Given this list of marker genes CAV1, HMGB1, CLEC12B, NLRC4, CD180, TAX1BP1, KLRC4, REG3G, RNF216, BIRC2, NFKBIA (NFKB inhibitor alpha), EIF2AK4, PTPN22, SYT11, RNF135, ITCH, KIR2DS2, NR1H4, IRF7, MNDA, POLR3F, EVPL, XRCC6, OAS3, MATR3, RAB11FIP2, OASL, DDX60, MAVS, NFKBIL1, POLR3G, AP3B1, CNOT7 (NCBI Gene Id 29883), RNF170, CARD16, OTUD4, USP15, GRN, DEFB114, PLA2G5, RNF144A, KLRC2, HSP90AA1, UNC93B1, CLEC7A, PELI1, PTPN6, PRKAA1, SELENOK, INPP5D, TRAF3IP2, NLRX1, MIR17, CXCL6, GSDME (NCBI Gene Id 1687), CD300H, RTN4, LSM14A, TRIM5, CR1, TRAF3IP3, YTHDF2, MIR200C, LY86, FBXO38, FLOT2, ZC3HAV1, PQBP1, TLR10, MAP3K7, PYDC1, KCNK6, SMIM30, BMP6, EIF4E2, KLRK1, ZDHHC11, EREG (epiregulin), METTL3, TRIM21, MAPK3, FOXP3, MIR146A, DDX41, CHUK, MIR20A, STAT5A, PTPN11, TRIM44, TLR3, CLEC6A, IL17A, SYK, PIK3R1, AKT1 (NCBI Gene Id 207), CD1D, CD37, GKN2, TBK1, USP18, CYBA (NCBI Gene Id 1535), PPP6C, NCF1, IL27, CD226, TSPAN6, MYD88, RNF31, A2M, KLRC3, SLC15A4, SLC15A3, DDX39A, RNF115, APPL2, DTX3L (NCBI Gene Id 151636), OTOP1, OTULIN, TREML4, RASGRP4, FCN1, NLRP1 (NLR family pyrin domain containing 1), CLEC4E, ARRB2, CARD8, TNFAIP3, HCK, MIR21, RNF125, IRF5, NMI, PAK1, PIK3AP1, NECTIN4, HLA-F, TLR5, PPP2R3C, SQSTM1, KLHL22, AHR, COLEC12, LILRB1, USP50, ZMPSTE24, FADD, IL15, CREBBP, EP300, CCDC134, HLA-E, FGL2, TRIM31, SFPQ, FFAR2, ECSIT, ATG12, PTPN1, MIR140, IRGM, LYAR, MMRN2, SMPDL3B, CALHM6, GFI1, SARM1 (NCBI Gene Id 23098), MBL2, HCFC2, LAMP1, NLRP10, PGC, SLAMF8, IRF3, PYDC2, TAB1 (NCBI Gene Id 10454), NR1D1, MAP2K6, DHX9, S100A9, HLA-A, PIM1, RSAD2, NFE2L2, TICAM2, TRIB1, VAV1, TRIM65, ZNRF1, CCDC92, GRB2, FBXL2 (NCBI Gene Id 26008), POLR3B, MAPKBP1, NOP53, ATG5, CD55, PAK2, TIGAR, RAET1G, PPP2CA, CD300E, KCNJ8, SPN, SIGLEC16, BCL10, TARBP2 (TARBP2 subunit of RISC loading complex), IL23R, MIR708, RBM47 (RNA binding motif protein 47), TRIM38, TRIL, PYCARD, NR1H3, IFIH1, ABHD17A, STMP1, NLRP3, RPS19, NINJ1, KCNK13, PPM1B, ZNFX1, TRAF3IP1, BECN1, IKBKB, NECTIN2, IRAK1, IKBKE, ESR1, FOXP1, TKFC, GBP2, COLEC10, APP, APOBEC3G, RNF34, TRIM41, SIRT2, AP1G1, MAPKAPK3, INS, FCRL3, MMP12, CEACAM1, SIGIRR, TLR1, PRKD1, MAPK8, CEP63, KLRB1, SERPING1, MIR520B, FYN, NPLOC4, IL23A, ARG1, ATAT1, CACTIN, CD14, TRIM11, RASGRP1, IFNB1, CREB3, ELP6 (elongator acetyltransferase complex subunit 6), HSPA1B, PLSCR1, PDCD1 (NCBI Gene Id 56179), IFNLR1, PPARG (peroxisome proliferator activated receptor gamma), MED1, TTLL12, SLC46A2, NAGK, MIR200B, TLR6 (NCBI Gene Id 10333), KAT5, USP17L2, CD300A, PRKCE, IRF1, MARCHF5, PAK3, MFHAS1, HLA-B, NEK7, LRRC19, CD274, SAMHD1, KLK3, DTX4, XIAP, SASH1, HSPA8, SERPINB4, STING1, HLA-G, GDI1, IL12A, CYLD, ZDHHC5, HSPA1A, TLR9, HPX, SH2D1B, GPR108, MIR26B, ANKRD17, MIR181B1, MEFV (NCBI Gene Id 4210), SCIMP, RAB7B, NLRP6, BPIFB1, MICB, NLRC5, HAVCR2, AIM2 (absent in melanoma 2), ADAM8, NOD1, PPT1, OPTN, GRAMD4, IL21, PRKDC, IRAK2, IRAK4, DAPK1, NCR1, TREX1, PJA2 (praja ring finger ubiquitin ligase 2), SPSB3, TIGIT, PTPN2, CD36, LGR4, TXK, NCR3, CADM1, SERPINB9, NLRP2B, APPL1, CSNK1A1, ERBIN, POLR3D, TREM2, PDPK1, ZDHHC3, UBQLN1, WNT5A, KLK7, LRRC14, AURKB, IL17F, KLRD1, SLC15A2, PML, DDX3X, LRSAM1, COLEC11, CASP8, SLC22A13, PARP9, PUM1, TLR8, SRC, LAG3, PYDC5, LACC1, RIPK2, LYPLAL1, ZDHHC4, MICA, TYRO3, RNF39, MIR19A, UFL1, PSPC1, HDAC6, SPI1, CPT1A, TOMM70, N4BP1, SLAMF6, NAIP, CD300C, MIF, IFI35, TNF, SLC19A1, ALPK1, AKIRIN2, TRIM25, TSPAN32, TRIM6, TRIM62, VSIG4, LILRA4, STAT1, EMILIN2, LY96, CDC37, TIFA, TIFAB, ACOD1, ZNRF4, SFN, PHB1, ARG2, SMPDL3A, USP27X, NR1H2, IL18RAP, LATS1, HLA-DRB3, LGALS9, LRCH4, LEP, DHX58, CPTP, DAB2IP, RBM14, SPINK5, CLPB, ZBP1, BIRC3, NOD2, TASL, MIR4691, LBP, LATS2, HSP90B1, BRCC3, TMEM126A, NLRP4, PVR, GPATCH3, TRIM3, LTF, AARS2, CLNK, ZDHHC9, GATA6, TLR4, MUL1, MR1, ZDHHC12, TLR7, POMC, TIRAP, CARD9, STAT2, GBP5, PARP1, USP38, APOBEC3F, CD160, INAVA, DHX33, ABHD8, UBE2K, FOSL1, FCN2, DUSP10, FAM3A, BANF1, DEFB118, PCBP2, ZCCHC3, NT5C2, USP5, S100A8, YWHAE (tyrosine 3-monooxygenase/tryptophan 5-monooxygenase activation protein epsilon), ERCC6 (NCBI Gene Id 282965), NONO, ISG15, KLK5, ERAP1, LYN, CX3CL1, TICAM1, LRP8, FCN3, TNIP1, IFI16, TRIM15, RELA, CGAS, TNIP2, RIGI, BTK, PUM2, IL12B, TRIM22, CCL5, SIN3A, ZC3H12A, FPR2, WASHC4, YWHAG, PYHIN1, TRIM56, F2RL1, HSPD1, NLRC3, OGT, PRKCA, PIK3R6, HEXIM1, KIR2DL4, RNF185, SH2D1A, SUSD4, HMGB2, HLA-DRB1, KLRC1, USP29, EIF2AK2, RAET1E, FCGR2B, APOE, FLOT1, LAMP2, LACRT, GIGYF2, MARK4, SEC14L1, CD96, DRD2, IL1B, IFNK, ADAR, PARP14, IL12RB1, YWHAZ, TGFB1, CRK, DNAJA3, STAT5B, ILRUN, IRF4, S100A14, CRTAM, ZDHHC1, KLRC4-KLRK1, RNF26, PTPRS, CFH, CASP1 (caspase 1), SCARA3 (NCBI Gene Id 7992), TYROBP, WDFY1, CTSS, MIR520E, C1QBP, LETMD1, XRCC5, HRG, EPG5, TRIM32, TRAFD1, TLR2, FGR, RIOK3, OAS1, CD300LF, GPS2, IPO5, PRDX2, HERC5, POLR3C, P2RX7, RFTN1, IL4I1, NAGLU, MIR210, PLCG2, DCST1, RPS6KA3, ZDHHC18, PHB2, TRAF3, UFD1, EMILIN1, SIRPA, ELMOD2, IRAK3, MAPKAPK2, CASP6, YTHDF3, MIR149, LILRA2 (leukocyte immunoglobulin like receptor A2), TRAF6 (NCBI Gene Id 7189), NFKBIZ, TNIP3, here is a description of the gene set: Human Gene Set: GOBP_REGULATION_OF_RESPONSE_TO_BIOTIC_STIMULUS Any process that modulates the frequency, rate, or extent of a response to biotic stimulus. species: Homo sapiens